The following is a description of a gene set: studied in species Mus musculus A structural unit of the synaptonemal complex found between the lateral elements. Mouse Gene Set: GOCC_CENTRAL_ELEMENT, and this is the list of marker genes: Syce2, Tex12, Sycp1, Tex11, Syce3, Syce1, 4930447C04Rik, Incenp